The following is a description of a gene set: Androgens are the determining factors for male development and behaviour in vertebrates. Reactome Pathway: Androgen biosynthesis studied in species Homo sapiens part of: Metabolism of steroid hormones, and this is the list of marker genes: POMC, SRD5A1, SRD5A2, HSD3B2, CGA, LHB, HSD3B1, HSD17B12, CYP17A1, SRD5A3, HSD17B3